Given this list of marker genes Adcy10, mt-Nd4, Atpsckmt, Ndufb10, Sdhd, Ndufs8 (NADH:ubiquinone oxidoreductase core subunit S8), Ndufa13, Ndufs3, Tmsb4x, Ndufb8, Ppara, Ndufb1, Fam3a, Eno1, Atp5f1b, Lipa, Ndufa1, Stoml2, Atp5if1, Sdha, Myc, Ndufc2, Ndufv3 (NCBI Gene Id 78330, NADH:ubiquinone oxidoreductase core subunit V3), Ndufb3, Ldhc, Atp5me, Ndufs4, Ndufa2, Ndufa3, Atp5f1a, Map2k1, Cox11, Atp5pb (ATP synthase peripheral stalk-membrane subunit b), Bcl2l1, Atp5mc3, Il4, Atp6v1a, Entpd1, Atp5mc1, mt-Atp8, mt-Atp6, Ndufb4, mt-Nd5, mt-Nd4l, Ldhd, Atp5pf, mt-Nd1, Ndufc1, Ndufs7 (NCBI Gene Id 75406), Eno1b (NCBI Gene Id 433182), Ndufb7, Atg5lrt, Ndufa11, Ndufa5, mt-Nd6, Aldoa, Ndufb2, Sdhc, Ndufs6 (NCBI Gene Id 407785), Atp5f1e, Ndufs1, Vcp, Prkn, Pid1, Atp5po, Ndufa12, Ndufa8, Uqcc3, mt-Nd2, Tgfb1, Atp5f1d, Nudt2, Dmac2l, Ndufa10, Ndufb11, Slc25a13, Ndufs2, Letmd1, Sdhb, Atp5mf, Slc25a12, Ak3, Ndufs5, Parp1, Ndufb5 (NADH:ubiquinone oxidoreductase subunit B5), Ndufa7, Atp5f1c, Ndufa6, Atp6-ps, Sphk2, mt-Nd3, Dnajc30, Atp5mg, Ndufb9, Antkmt, Ndufab1, Hnf1a, Atp5mc2, Ndufa9, Atp5pd, Ndufv2, Ndufb6, Stat3, Trem2, Ndufv1, here is a description of the gene set: species: Mus musculus The chemical reactions and pathways resulting in the formation of ATP, adenosine 5'-triphosphate, a universally important coenzyme and enzyme regulator. Mouse Gene Set: GOBP_ATP_BIOSYNTHETIC_PROCESS